The following is a description of a gene set: Human Gene Set: MYOGENIN_Q6 Genes having at least one occurrence of the motif RGCAGSTG in the regions spanning 4 kb centered on their transcription starting sites. This matches the MYOG transcription factor binding site V$MYOGENIN_Q6 (v7.4 TRANSFAC). species: Homo sapiens, and this is the list of marker genes: MYF5, IGF2BP1, RTKN, RAB35, SLC26A10P, TNFAIP1, ARID1A, EXOC5, CNP, PTPRJ, LOXL4, CYLD, ABTB3, NBL1, ELAVL3, HRC, CHRNE (NCBI Gene Id 83405), HID1, S100A8, RRAD, GPR37L1, SV2B, UBTF (upstream binding transcription factor), CD247, RRAGC, NEDD4L, PIP4K2A, ATOH8, TJP1, SLC37A4, BNIP3, SRCIN1, DAAM1, HSD11B2, PSMC3IP, RAPGEF3, CDH5, LRATD1, SYNE3, NDUFA4L2, SYT6, SLC30A10, TBX10, DDHD1, ZBTB16, P3H3, UNC45B, WDR25, POLR3GL, OSR1, WNT10B, JUP, EPHA2, ST3GAL5 (NCBI Gene Id 8869), MFSD13A, BEST3, CADM1, TMEM125, ELK3, IFT20, ALG6, EPHB2, TTC13, PKN1, KCNQ4, GJA5, FMNL1, FBLIM1, NKX6-2, RUNX3, C1QA (complement C1q A chain), CYRIA, ZFP36L1, EPN2, RNF152, CASQ1, CRIP2, LMOD1, VAMP2, FLRT1, SOST, TRPV3, DPF3, NOL4, NEGR1, KCNIP3, ZFYVE9, TGIF1, DTNB, CIC, MAMSTR, CYP26A1, RNF19B, CCDC85B, TEAD4, GGNBP2, CABP1, ETFB, ANKRD1, GARRE1, SCNN1G, SHCBP1L, EFNA4, INHA, ADAM11, TUFT1, UACA, KCNIP2, FBXL20, SORT1, ATP6V0C, TPCN1, DES, STIM1, ZBTB25, ANKRD2, SLC30A3, RNF213, GNG8, XYLT1, POU3F3, ALG10, TNFAIP8L1, PICALM, DNHD1, DCT, CDKN2C, PODN, CACNB1 (calcium voltage-gated channel auxiliary subunit beta 1), CREBL2, VWA1, ITGA6, GPA33, GRIK3, GNB3, PCF11, MANEAL, SORCS1, KCNQ1DN, ERH, RUSC1-AS1, CLC, LRP5, PAK6, SOWAHC, PCGF5 (polycomb group ring finger 5), IGSF3, COL2A1, MAST1, ENO3, ESCO1, TUBB4A, SERTM1, ZCCHC24, EIF4G2, SH3BGRL3, HEYL, DMPK, KAZALD1, GFRA1, MACROD1, TNNT3, ARV1, SPTB, ARHGAP33, FXYD1, GPR162, ZFP91, RPLP1, DBP, CDON, BCAS3, FGR, LINC03124, CDH3, MCMBP, SEPTIN10, SIPA1, DDAH1, ADAMTS8, VEZF1, GGN, STK40, DDIT4, EDC4, SPI1, KCNA2, SELPLG, PSTPIP1, COL4A3, ITSN2, LDB3, COL1A1, DOCK9, SYT17, KRT75, SPACA6, WFIKKN2, C11orf87, AARSD1, ENKD1, SLC39A9, AGO1, STAT5A, AXL, RHOD, FITM1, SYT4, SMOC1, OLFM2, BMPR2, EPB41L5, MAP1A, DGKZ, KRT15, SYNPO2L, CCDC177, FAM98A, ERF, PLEKHA4, WDTC1, NOL9, AP5M1, IQCD, HMGA2, CA7, LRP10, ATP5F1B, EMX1, HOXB1, SLC35F2, EMSY, SGIP1, ALDH1A2, TGFB3, IGSF8, SMAP2, RUNDC1, ATP1B1, PAX2, MBD6, TAS1R1, TRIM8, RNF220, ZBTB18, TRIM62, PARD3B, PRKACA, DLL4, SEZ6, COL4A4, CCNL2, SUMO2, AQP5 (aquaporin 5), RARA, HTN1, FSCN2 (fascin actin-bundling protein 2, retinal), TIGAR, HMGN2